The following is a description of a gene set: species: Mus musculus Mouse Gene Set: GOBP_MULTICELLULAR_ORGANISMAL_REPRODUCTIVE_PROCESS The process, occurring above the cellular level, that is pertinent to the reproductive function of a multicellular organism. This includes the integrated processes at the level of tissues and organs., and this is the list of marker genes: Gtsf1, Aurka, Llcfc1, Trim28, Sppl2c, 1700013H16Rik, Spag16, Spaca1, Ddb1, Pias1, Zfp449, B4galnt1, Celf1, Ttll8, Hyal5, Wdr54, Gm28576 (NCBI Gene Id 101056210), Ccl2, Gjb3, Ppard, Xlr3a (NCBI Gene Id 22445), Acsbg2, Fancl, Paqr5, Tnfaip6, Dmd, Stox2, Stat5b, Tug1, Cfap70, Akap9, Serpine2, Spata24, Stk33, Izumo1r, Cfap119, Adig, H2aj, Cit, Acvr1, Top2a, Acrbp, Hmga1, Pik3ca, Prmt7, Mertk, Bcap31, Gli1, Klhl10, Iftap, Avpr1a, Atp1a4, Svs3b, Esr1, Mbd2 (methyl-CpG binding domain protein 2), Gm20820, Ccdc87, Fignl1, Rln1, Ptgdr2, Tnp1, Cep128 (NCBI Gene Id 75216), Prdm1, Atn1, Tmem203, Strbp, Garin1a, Aplp2, Tex11, Vmn2r116, Herc2, Ttll3, Hoatz (HOATZ cilia and flagella associated protein), Kdm5a, Ghrl, Shb, Prl, Zfx, Hsf5, Mta2, Ihh (Indian hedgehog), Spin2c, Agrp, Catspere1, Catsperd, Dmrt1, Klc3 (kinesin light chain 3), Dnd1, Tcp11x2, Mtor, Crem, Sirt1, Cfap61, Nos3, Magoh, Ift20, Mettl3, Cdkn1c, Foxj2, Prm2, AU040320, Hfm1, Katnal1, Morc2b, Prss37, Pdgfra, Tspan8, Ptk2b, Tdrd7, Meioc, Slc19a2, Gm5935, Zfp39, Hmga2, Cfap206, Kash5, H2ax, Nodal, Taf4b, A2m, Cyp1b1, Tbc1d20, Prss44, Fzd4, Gm5934, Cd9, Zscan21, Sufu, Armc3, Ct55, Agt, Acox1, Slc9c1, Ghsr, Syne1, Npr2, Spata32, Xist, Iqcn, Folr1, S100a11 (S100 calcium binding protein A11), Trp53, Notch1, Fhad1, Dmxl2, Bsph1, Xlr4b, Cep131, Sos1, Txndc2, 2610005L07Rik, Celf3, Gpx4, Adam24, Msh4, Zscan2, Il11ra1, Bsph2 (NCBI Gene Id 77684), Lhcgr, Brme1, Crebrf, Slc6a4, Tacr1, Cdyl, Gnasas1 (NCBI Gene Id 56802), Gopc, Abcg2, Pgam2, Kalrn, Shh, Tesk1, Sox3, Oxtr, Hoxa11, Cfap52, Tarbp2, Ednra, Cxcr4, Ncaph, Gm21627, Dnmt3a, Drc1, Bcl6, Sohlh2, Avp, Parp11, Catsper3, Fev, Bbs4, Cyp26b1, Adcy7, Itgb1, Prm1, Odf1 (outer dense fiber of sperm tails 1), Btbd35f1, Enpp2, Cimap1a, Pebp1, Sfmbt1, Spag6, Tsnaxip1, Xlr5a, Meikin, Trpc2, Diaph2, Jam2, Atat1 (alpha tubulin acetyltransferase 1), Spef2, Ptgs2, Hoxa10, Cited2, Septin2, Vdr, Slc26a6, Pdilt (NCBI Gene Id 71830), Cabs1, Ift27, Bcl2, Ccdc38, Slc26a8, Glipr1l1, Spo11, H2al2a, Abat (4-aminobutyrate aminotransferase), Wdr48, Slc25a31, Skil, Stra8, Grb14, Hexb, Tex15, Psma8, Oas1d, Wt1, Spata9, Hrob, Kat5, Ggt1, Usp42, Mov10l1, Cox7b2, Sod1, Tnp2 (transition protein 2), Ccna1, Ddo, Cfap53, Dsg2, Ube2j1, Spdya, Nr5a1, Rxra, Pla2g4a, Gm29554, Rnf151, Vipas39, Pygo2, Tut7 (terminal uridylyl transferase 7), Catsperz, Shbg, Cep57, Poc1a, Tslrn1, Igf1r, Vps13b, Xlr3b, Nkapl, Psme4, Ptx3, Upf3a, Ccnyl1, Dnaja1, Map7, Nr3c1, Zfp296, Tdrd12 (NCBI Gene Id 73691, tudor domain containing 12), Ctsb, Brdt (bromodomain, testis-specific), Garin5b, Mlh1, Dhh, Prdm14, Gm4297, Tle3, Parp2, Retn, Adgb, Wipf3, Fsip2, Tssk4, Rec8, Rbx1-ps, Cfap54, Rsph6a, Klk14, Adamts16, Sstr2, Ada, Dmrta1, Gja1, Rxfp2, Uchl1, Kif18a, Adcyap1r1, Egr1, Gnaq, Eif2s2, Gm20911, Tle6, Utp14b, Serpina5, Nr2c2, Pacrg, Suv39h2, Catspere2, Herc4, Mlh3, Adamts1, Ptch1, Pde4d, Rgs2 (regulator of G-protein signaling 2), Bckdk, Ptprn, Gal, Gm1140, Yy1, Npm2, Rad21l, Adam18, Gm29866, Chtf18 (NCBI Gene Id 214901), Zpbp (NCBI Gene Id 74977), Ropn1l, Stc1, Ybx3, Sfrp1, Xrn2, Prl8a2, Ccdc146, Rimbp3, Plcb1, Garin4, Herpud2 (NCBI Gene Id 80517), Calca, Cfap47, Ndc1, Adam26a, Shisa6, Jag2, Zar1, Dnmt3b, Eif2s3y, Tnk2, Tpgs1, Ctsl, Dnmt3l, Ttll1 (NCBI Gene Id 319953), Has2, Lrguk, Spata16, Gmnc, Rab1a, Rbx1, Gm38999, Adad2, Hoxa9, Ttk, Ercc1, Gdf10, Msh2, Mas1, Tppp2, Il1a, Nup210l, Limk2, Pdcl2, Yif1b, Clock, Adnp, Adad1, Spmip6 (NCBI Gene Id 73721), H3f3b, Nme5, Hyal3, Gsr, Pde3a, Plekha1, Tmem232, Prdx4, Tssk3, Sh3pxd2b (SH3 and PX domains 2B), Garin2, Tssk6, Ovol1, Tmem95, Fbxw11, Fancf, Lyzl6, Nos2, Spata6l, Nphp1, Ppp1r1b, Cntd1, Iho1, Gm6121, 3830403N18Rik, Tmem119, Actl7a, Tdrp, Spata6, Cnot7, Itga3, Akt1, Tmprss12, Oprk1, Smad4, Cfap65, Neurl1a, Gm773, Neurl4, Bmp8a, Spag8, Mettl14, Tpst2, Gm14525, Izumo3, Scaper, Cfap57, Dcaf17, Ago4, Thrb, Agfg2, Washc5, Qki, Slirp, Boll, Mcidas, Esp1, Mycn, Xlr4c, Ift81, Sly, M1ap, Ddx4, Mkrn2, Creb3l4, Dzip1, Ndrg3, Prnd, Nr0b1, Fbxo5, Ttc12, Odf4, Kit, Sbf1, Akap4, Folr2, Dhx36, Taf7l, Angpt2, Paqr7, Dcst1, Cylc2, Clgn, Tsnax, Ctnnb1, Gabrb1, Pou4f2, Trp63, Galntl5, Lrrk2, Slco4c1, 4930447C04Rik, Aspm, Lamp1, Ptpn11, Spire1, Cdk16, Cfap221, Nsun2, Arrb2, Ccnb2, Lrrc8a, Gm21865, Ap3b1, Frey1, Slxl1, Ccdc63, Bmp8b, Ptgds, Dmrtc2, Ctcfl, Sry, Catsper2, Fndc3a (NCBI Gene Id 76636), Spata2, Gm21095, Hsf2, 1700102P08Rik, Gm21760, Asb17, Rxrb, Plk1, Tex19.2 (NCBI Gene Id 70956), H1f7, Brip1, Cylc1, Gal3st1, Ddias, Spocd1, Stau1, Schip1, Ndc80, Xlr3c, Runx1, Thra, Nanos1, Sycp3, Zfp628 (zinc finger protein 628), Spatc1l, Spaca3, Pygo1, Btbd18, Ubb, Nanos2, Ccdc42, Fanca, Atrx, Misfa, Oosp2, Prss42, Nlgn4l, Ankrd49, Tyro3, Drd1, Spem1, Cdc25c (NCBI Gene Id 12532), Mir34c, Wee2, Trip13, Oxt, Airn (antisense Igf2r RNA), Htt, Spaca6, Ccin, Oog1, Cyp1a1, H3f3a (NCBI Gene Id 15078), Garin5a, Gorasp2, Gm28919, Spesp1, Mir34b, Zc3h14 (zinc finger CCCH type containing 14), Gm20817, Foxj3, Sox30, Csmd1, Ldoc1, Armc2, Spin4, Tex14, Pank2, Cfap43, Cnbd2, Mmp2, Gm2030, Kdm1b, Krt9, Catsper4, Hspa1l (NCBI Gene Id 15482), Arrb1, Ift25, Etv6, Mei4, Prdm9, Izumo1, Sstr3, Dcaf13, Rb1, Zglp1, Prm3, Med1, Ppp1cc, Meiosin, Styx, Ropn1, Tbc1d21, Spin1, Cfap157, Tlk2, Spire2, Junb, Spata31, H3f4, Hspa8, Ccdc34, Mast2, Zfp148, Sox17, Rnase9, Tgfbr1, Erbb2, Defb37, Tsix, H2bc1, Ctcf, Ncoa1, Ccdc62, Rad23b, Gm5168, Tssk1, Ar, Sycp1, Prok2, Tbpl1, Alkbh5, Armc12, Setx, Sun1, Vps54 (NCBI Gene Id 245944), Paip2, Dnah1, Dlec1, Trim75, Morn2, Dnali1, Tdrd6, H1f6, Piwil2, Fer, Mecp2, Mybl1, Ift56, Slx, Agfg1, Gm28961, Slc26a3, Khdrbs1, Cib1, Ctdnep1 (NCBI Gene Id 67181), Rbm46, Gsk3a, Men1, Amh, Tdrkh, Hsf1, Bnc1, Spag4, P2rx1, Ska3, Kitl, Adam7, Ythdf2, Pcsk4, Spata20, Meg3, Gm28870, Ndn, Gm21858, Piwil1, Fst, Gm20824 (predicted gene, 20824), Pabpc1l, Selenof, Dedd, Large1, Phc2, Fancd2, Ppp3cc, Sstr1 (somatostatin receptor 1), Hook1 (NCBI Gene Id 77963), Bcas2, Zfp57 (zinc finger protein 57), Msh6, Zar1l, Nme8, Hormad1, Tssk2, Etv5, Aff4, Cntrl, Lgr4, Spata25, Lztfl1, Gm20736, Majin, Osbp2, Ppp3r2, Tekt4, Gmcl1, Xlr5b, Ntrk1, Fsip1, Ak7, Gata4, Piwil4 (piwi-like RNA-mediated gene silencing 4), Rbp4, Spata22, Cul4a, Meiob, Rhbdd1, Atm, Pgr, Rai14, Patz1, Eed, Tgfb1, Jam3, Rnf17, Lif, Adam25, Bax, Gdf9, Mael, Xlr4a, Pfn4, Ash1l, Mgat4d, Gm5169, Spink1, Cfap69, D1Pas1, H19, Nr6a1, Fancg, Ptafr, Nicol1 (NCBI Gene Id 381633), Gm7958, Sp3, Sycp2, Adam1a, Cftr, Emp2, Sp1, Ing2, Igf1, Spag17 (sperm associated antigen 17), Foxc1, Septin4, Pcyt1b, Stau2, Nup62, Lep, Gm10230, Bltp1, Zfy2, Defb1, Acsl4, Gk2, Fshr, Mst1, Sox9, Poc1b, Rec114, Gm21996, Kmt2d, Smchd1, Kdm2b, Mkks, Pmfbp1, Ubr2, Immp2l, Src, Cfap97d1, Fkbp6, Edn2, Zfp37, Asz1, Tppp3, Rps6ka2, Meig1, Stk11, Stc2, Ptn, Hspa2, Ace2, Ccr6, Myh9, P2ry2, Pld6, Dbh, Ttc21a, Bbs2, Snrpa1, Cyp27b1, Nek1, Ska2, Gm20870, Sgpl1, Pxt1, Ddx25, Eqtn, Acr, Ros1 (NCBI Gene Id 19886), Slit3, Txnrd3, Fosl1, Kpna6, Tesmin, Morc1, Arrdc5, Rhox8, Npas1 (NCBI Gene Id 18142), Mapk3, Ccnb1, Lin28a, Msh5 (NCBI Gene Id 279936), Ednrb, Npy5r, Paqr8, Hdac4, Nppc (NCBI Gene Id 18159), Odad3, Ace, Rara, Mycbpap, Hadh, Ncaph2, Gm10488, Ggn, Gsk3b, Inhbb, Six5, Dcst2, Klf17, Tial1 (NCBI Gene Id 68078), Xlr5c, Zfp830, Tut4, Svs3a, Tgm4, Spmip7, Mapk8ip2, Grin1, Prdx3, Gas2, Arid4a, Fuom, Foxa3, Smad1, Brca2, Serpinf1, Nectin2, Hps1 (NCBI Gene Id 54334), Gm20890 (NCBI Gene Id 434941), Zfp42, Ereg, Slc4a2, Nobox, Mea1, Sun5, Eif4g3, Ythdc2, Casp3, Kiss1, Sohlh1, Tmed2, Zmynd15, Wnt3 (NCBI Gene Id 22415), Taar5, Pax5, Zcwpw1, Ppp2r1a, H1f1, Efcab9, Hmgb2, Rpl10l, Ccdc136, Tssk5, Gm2012, Wdr77, Sox8, Zfp41 (NCBI Gene Id 22701), Arhgap33os (NCBI Gene Id 381868), Pcna, Kctd19, Gm1993, Nlrp14, Insl3, Igf2r, Kdm3a, Mapk1, Bmpr2, Galnt3, Garin3, Hpgd, Cyp11a1, Abhd2, Ssty1, Rsph1, Map2k6 (mitogen-activated protein kinase kinase 6), Mroh2b, Btg1, Tcf23, Esp22, Sec23ip, Has1, Bscl2, Mfsd14a, Inpp5b, Sirt2, Cabyr, Gjb2, Mamld1, Cabcoco1, Lsm14b, Grn, H1f9, Mdk, Mcmdc2 (minichromosome maintenance domain containing 2), Ube2q1, Garin1b, Prkg1, Dld, Rps6kb1, Iqcf1, Hsf2bp, Pln, Syce3, Septin14, Siah1a, Ttll5, Cip2a, Mastl, Txndc8, Atp2b4, Ncoa2, Arid4b, Adrm1, Sgo2a, Catsper1, B4galt1, Shcbp1l, Drc7, Gja10, Grk2, Tesk2, Bik, Ccno, Lrrc46, Septin1, Ptgis, Epor, Cenpe, Spam1, Mos, Spem3, Hcn1, Smcp, Casp2 (NCBI Gene Id 12366), Cetn2, Tdrd9, Nr2f2, Hpgds, Kcnq1ot1, Afp, Pgm3, Zmiz1, Alms1, Bsg (basigin), Ska1, Chd5, Bcl2l11, Ppp1r9b, Cfap58, Tmf1, Rpl39l, Hdac2, Il18, Th, Topaz1, Mns1, Zfp541, Zfp35, Cadm1, Stat5a, Tdrd5, Lgr5, Semg1, Vdac3, Gabrb3, Gamt, Nhlh2, Oca2, Zdbf2, Ica1l, Mmp19, Vip, Calr3, Slc22a16, Oprm1, Crtap, Tdrd1, Bbof1, Ezhip, Epc1, Rad51c, Zpbp2, Washc1 (WASH complex subunit 1), Cckbr, Tbata (NCBI Gene Id 76570), Adam1b, Zbtb16, Pafah1b1, C2cd6, 4930451I11Rik, Nrip1, Inhba, Fancc, Umodl1, Xlr, Sebox, Cdh1, Prkaca, Ndp, Ccdc33, Gm21117, Ift88, Chrna7, App, Gm21294, Mir449c, Tm9sf5, Ube2b, Havcr2, Gnas, Chn2, Adamts2, Cbs, Acvr2a, Calr, Cyp51, Esr2 (estrogen receptor 2 (beta)), Cntln, Zmynd12, Insl6, Mir449b, Spmap2, Ddx3x, Spata46, Dkkl1, Pten, Pnldc1, Ddx3y, Fam209, Dmc1, Dazl, Csnk2a2, Gm28102, Spata19, Axdnd1, Pde5a, Edn1, Fscn3, Apob, Dazap1, Mcm8, Larp7, Smad5, Usp26, Fbxo24, Odf2, Hmx3, Slc22a14, Dnaaf3, Zp3, Catsperg2, Egfr, Rnf2, Dpcd, Scmh1, Lypd4, Ggnbp2, Lyzl4, Spink2, Marf1, Prss43 (serine protease 43), Drd4, Tuba8, Bcl2l1, Fmn2, Cfap91, Terb2, Pithd1, Pla2g3, Tekt3, Rspo1, Ehmt2, Cldn11, P2ry1, Mcm9, Brinp1, Tsga8, Rnf8, Pafah1b2, Dnhd1, Rgn, Nkd1, Wnt4, Tcp11, Cxcl12, Gm28510, Rfx2, Kmt2b, Catsperb, Tex19.1, Dpy19l2, Slc9a8, Ube2a, Adcy10, Septin6, Pum1, Mstn, Spaca5, Ptger4, Parp1, Afg2a, Septin7, Sass6, Ccnb1ip1, Mfn2, Mir449a, Cfap44, T, Actl9 (actin-like 9), Rad18, Npas3, Orc4, Racgap1, Ccdc159, Ythdc1, Gm29276 (predicted gene 29276), Mei1, Ddx20, Foxo3, Bmpr1b, Bag6, Spag6l, Figla, Fxr1, Golga3, Kat8, Dicer1, Cdc25b, Nanos3, Pafah1b3, Rnf114, Spinkl, Gm20843, Cnr1, Ggnbp1, Crkl, Rps6, Ssh2, Fshb, Iqcg, Nr5a2, Drd5, Cxadr, Gpr149, Bmp4, Axl, Bmal1, Ybx2, Prss21